Given this list of marker genes USB1, DKC1, INTS12, TOE1, METTL4, INTS5, EXOSC5, LARP7, INTS8, NHP2, INTS1, INTS4, INTS9, EXOSC7, INTS11, INTS3, EXOSC4, MEPCE (methylphosphate capping enzyme), METTL16, FTO, INTS10, INTS14, INTS6, INTS6L (NCBI Gene Id 654032), SAGE2P, EXOSC6 (exosome component 6), INTS7, EXOSC3, EXOSC8, SAGE1, INTS13, NOP10, EXOSC9, TUT1, EXOSC2, INTS2, here is a description of the gene set: Human Gene Set: GOBP_SNRNA_PROCESSING studied in species Homo sapiens Any process involved in the conversion of a primary small nuclear RNA (snRNA) transcript into a mature snRNA molecule. The primary function of snRNAs is processing pre-messenger RNA in the nucleus. They have also been shown to aid in the regulation of transcription factors (7SK RNA) or RNA polymerase II (B2 RNA), and maintaining the telomeres.